The following is a description of a gene set: species: Homo sapiens Reactome Pathway: The AIM2 inflammasome part of: Inflammasomes AIM2 is a member of the PYHIN or HIN200 family. It has a C-terminal HIN domain which can bind double-stranded DNA (dsDNA) and a PYD domain that can bind ASC via a PYD-PYD interaction. In cells expressing procaspase-1, The interaction of AIM2 with ASC leads to recruitment of procaspase-1 forming the ASC pyroptosome which induces pyroptotic cell death by generating active caspase-1. Data from AIM2 deficient mice indicates that the AIM2 inflammasome is a nonredundant sensor for dsDNA that regulates the caspase-1-dependent maturation of IL-1beta and IL-18., and this is the list of marker genes: AIM2, CASP1, PYCARD